The following is a description of a gene set: Genes negatively differentially expressed in cell type: MigDC (migratory dendritic cell) upon treatment with cytokine: IFN-γ in mouse lymph nodes in vivo. studied in species Mus musculus from publication Cui A, Huang T, Li S, Ma A, Pérez JL, Sander C, Keskin DB, Wu CJ, Fraenkel E, Hacohen N (PMID 38057668) Cytokines mediate cell-cell communication in the immune system and represent important therapeutic targets. A myriad of studies have highlighted their central role in immune function, yet we lack a global view of the cellular responses of each immune cell type to each cytokine. To address this gap, the authors created the Immune Dictionary, a compendium of single-cell transcriptomic profiles of more than 17 immune cell types in response to each of 86 cytokines (>1,400 cytokine-cell type combinations) in mouse lymph nodes in vivo. A cytokine-centric view of the dictionary revealed that most cytokines induce highly cell-type-specific responses. For example, the inflammatory cytokine interleukin-1β induces distinct gene programmes in almost every cell type. A cell-type-centric view of the dictionary identified more than 66 cytokine-driven cellular polarization states across immune cell types, including previously uncharacterized states such as an interleukin-18-induced polyfunctional natural killer cell state. Mouse Gene Set: CUI_MIGDC_IFNG_RESPONSE_DN, and this is the list of marker genes: Hspa1b, Mt1, Tbc1d4, Rptor, Hspa1a (NCBI Gene Id 193740), Dusp1